The following is a description of a gene set: Human Gene Set: MAML1_TARGET_GENES studied in species Homo sapiens from publication Yevshin I, Sharipov R, Kolmykov S, Kondrakhin Y, Kolpakov F (PMID 30445619) Genes containing one or more binding sites for (MAML1) in their promoter regions (TSS -1000,+100 bp) as identified by GTRD version 20.06 ChIP-seq harmonization., and this is the list of marker genes: CCDC88B, KCNJ16, MT-TP, CD36, LINC02724, RHOG, PTPA, LINC01353, TFEB, ITGAL, CD79B, BCL9L, TMPRSS15, UNKL, GSDME, FCHO1, LIMD2, NADK, EIF4ENIF1, ZEB1, ENSG00000265222, ENSG00000226281, PIK3AP1, HLA-DMB, ARHGAP4, SIRT6, TYW1, GPR18, LDLRAD4, CD72, NANOS3, ACOXL, FKTN, TMX3, LY86, ZNF687, ENSG00000226571, RPL31P51, SHANK2, MLEC, EVL, MIR142HG, BFSP2, RPL17P2, SLC4A5, BACH1, RHEX, DAAM1, PEX13, IRAG2, CYBA, RHBDF2, TLR9, SAT1-DT, DRAM2, AGBL5, RNU6-163P, TMEM63A, SNRPEP5, ARHGAP31-AS1, SIPA1, LPAR5, KLHL20, POMP, TYW3 (tRNA-yW synthesizing protein 3 homolog), TET3, SBNO1, AFF3, LINC00323, KIF18B-DT, LINC02695, RASGRP2, CDK17, COX7CP3, NR3C1, SFTPB, RN7SL38P, RNU2-6P, DNASE1L3, IGLJ2, RUNX3, PASK, SCAMP1, PLEKHA2, MIR4425, MYBPC2 (myosin binding protein C2), ZEB2-AS1, MOB3A, ZNF398, KMT2A, BCL2A1, QTRT2, CXCR5, IL6R-AS1, ADAT3, MZB1, MT-TT, MIR155HG, MME, SH3BP1, MAP1LC3B2, CCL4 (NCBI Gene Id 6351), MIR4655, DDX39B, ENSG00000235979, YARS1, ST3GAL1, LINC01624, DENND1C, TMEM37, FCRL3, CAMP, CHRM3-AS2, LINC02028, RGS20, RN7SKP249, CIRBP, GPR158-AS1, MKNK2, HTR3A, LCN10, ENSG00000260132, LINC02422, NEUROG2, FGFRL1, RTF2, MS4A6A (NCBI Gene Id 64231), IL21R, NAPA, TBRG4, IRF8 (interferon regulatory factor 8), GOLM2, TEDC2-AS1, USP7, GAPT, TNFRSF17, ZEB2, MIR4645, NAPG, LINC02090, PDE4D, PUS10, POU2AF1 (POU class 2 homeobox associating factor 1), LINC02909 (NCBI Gene Id 196415), TLCD1, LY86-AS1, RAB30, CEACAM1, NAPSB, TXNIP, RASGRP3, OST4, RPL34P6, DTX1, FCMR, TRIM38, FUNDC2, SH2D3C, F8, ECE1, KIF18B, RCOR1, SLC22A15 (NCBI Gene Id 55356), ADAM7-AS1, ANGPTL6, SEPTIN9, EBI3, LSP1, CACNA1D, WFDC21P, LINC02642, ANKRD24, MIR4432HG, HES4, SYVN1, RIMS2, TMEM243, FGD3, CSK, IL16, ENSG00000231424, SBDS, EDDM3DP, RYR3, NACA, CD53, SLC33A1, PLEK, DTNB-AS1, PTK2, TLE4, CD19, MGAT1, LZTFL1, SELPLG, FKTN-AS1, OPA3, RNASE6, SNX11, LNCATV, ZSCAN16-AS1, OTUD5, TOR1AIP1, ZFAT, MIR6813, P2RX1, CCDC102B, PLEKHG2, ICAM2, BLK, IGLJ5, MTCO3P12, TLR1, SEC14L1, NUDT17, LINC02391, SH3TC1, SPIB, MTCO3P47, LINC02579, GNA15-DT, GSAP, PAN2, SDC3, ARHGAP25, SNORA37, MIR4513, NIBAN3, SCAMP4, ADAMTSL4-AS1, CCL3, S1PR2, DBNL, IGKC, NFATC1, ENSG00000236403, JDP2, FCER2, LINC01685, NDUFS7, LINC02175, RPL7P50, SLC1A4, BCL2L13, POLR1F, IGKV1D-8, LRIG1 (NCBI Gene Id 26018), CD69 (NCBI Gene Id 969), MIR1260B, CYB561A3, LINC03040, DGKA, CFAP97, JUP, ISG15, TXNDC12, USP7-AS1, LINC01215, IKZF2, IGLV7-43, NFAT5, MAPRE2, LFNG, RNU6-797P, RN7SL473P, HES1, GADD45B (NCBI Gene Id 4616), LINC02977, CTSZ, UBAC2, TESK2, LINC02924, SAT1, ITGB7, NUTF2, DNMT1, COX4I2, IGLV7-46, DDX39B-AS1, LINC00511, REL, UQCRC2, MS4A1, SNX25, IL23A, RSL24D1P11, P2RX5-TAX1BP3, ZNF831, ABCA6, ARHGAP45, ZNF101, LINC03034 (NCBI Gene Id 648835), DUSP2, CD1D, IGLV8-61, C12orf42, LINC01480, IL4I1, SLBP, BIRC3, PRKCH, COA1, NSMCE3, GPER1, LYRM4 (LYR motif containing 4), EPN2-AS1, TXNDC11 (NCBI Gene Id 96770), NEK8, ERBIN-DT, NEIL2, ST6GAL1, CYBC1, GTPBP8, CD37, MIR384, C15orf62, BRK1P2, MEMO1, P2RX5, MIR3150BHG, CIITA, HDAC7, GPSM3, PEX5L-AS2, NEDD9